The following is a description of a gene set: Reactome Pathway: Impaired BRCA2 binding to RAD51 A critical function of BRCA2 is to bind RAD51 and nucleate RAD51 filament formation on single-stranded DNA. BRCA2 has two regions that interact with RAD51: 8 BRC repeats encoded by exon11 and a C-terminal RAD51 binding domain called TR2. species: Homo sapiens part of: Defective homologous recombination repair (HRR) due to BRCA2 loss of function, and this is the list of marker genes: WRN, HUS1, RAD1, RMI1, BRCA2, SEM1, TOPBP1, BARD1, TOP3A, MRE11, ATRIP, RAD51, RAD17, RAD9A, RPA2, RBBP8, RAD9B, RFC3, RAD50, RMI2, RFC5, BLM, KAT5, RFC2, RHNO1, BRIP1, EXO1, RPA3, BRCA1, NBN, RFC4, ATM, RPA1, DNA2, ATR